Given this list of marker genes Adrb2, Chrna1, Igf2, Mstn, Actn3, Vps54, Dll1, Tll2, Rps6kb1, Mtm1, Crhr2 (NCBI Gene Id 12922), Col6a1, Chrnd, here is a description of the gene set: The increase in size or mass of a skeletal muscle. This may be due to a change in the fiber number or size. species: Mus musculus Mouse Gene Set: GOBP_SKELETAL_MUSCLE_TISSUE_GROWTH